The following is a description of a gene set: AA metabolism. species: Homo sapiens Human Gene Set: MODULE_78, and this is the list of marker genes: OAT, ALDH4A1, GSTZ1, QDPR, GCSH (glycine cleavage system protein H), GOT1, ALDH6A1, PTS (NCBI Gene Id 5805), GCH1, PAH, GOT2, AMT, ASS1, HPD, MTHFD1, CAD, FAH, ASPA, GAMT, GATM